Given this list of marker genes NR1D2, PAQR8, NR1H3, ESRRB, NR3C2, ABHD2, PPARG, NR6A1, NR2F2, HNF4A, NR1I3, NR4A3, NR1H4, PPARD, RARB, NR1H2, ESR1, PAQR7, GPER1, PPARA, BACH1, PDE3A (NCBI Gene Id 8080), RXRA (retinoid X receptor alpha), RORA, NR5A2, SREBF1, AHR, RXRG, NR2F1, STAT3, RARA, PGR, ARNT, RORC, THRB (thyroid hormone receptor beta), AHRR, NR4A2, NR2E1, NR3C1, RORB, RXRB (retinoid X receptor beta), ESRRG, NR5A1, OR51E2, ESR2, NKX3-1, PGRMC2, NR2C1, THRA, ESRRA, NR2C2, VDR, NR2E3, HNF4G, NR1D1, NR2F6 (nuclear receptor subfamily 2 group F member 6), AR, RARG, NR4A1, NR1I2, here is a description of the gene set: species: Homo sapiens Human Gene Set: GOMF_LIGAND_MODULATED_TRANSCRIPTION_FACTOR_ACTIVITY A DNA-binding transcription factor activity regulated by binding to a ligand and that modulates the transcription of specific genes and gene sets. Examples include the lac and trp repressors in E.coli and steroid hormone receptors.